The following is a description of a gene set: species: Homo sapiens Nuclear or cytoplasmic aggregates of substances in red blood cells. Erythrocyte inclusion bodies Human Gene Set: HP_ERYTHROCYTE_INCLUSION_BODIES, and this is the list of marker genes: RPSA, HBB, HBA1, GPX1, HBA2, ABCB7, PUS1, CASK, FADD, G6PD, STIM1